The following is a description of a gene set: Neighborhood of FRK fyn-related kinase in the MORF expression compendium studied in species Homo sapiens Neighborhood of FRK Human Gene Set: MORF_FRK, and this is the list of marker genes: AVP, SAA4, ODF2, ORC4, MYBPH, OPHN1, SPAG8, SSX2IP, P2RY6, RPGRIP1, ASTN1, PPP6R2 (NCBI Gene Id 9701), ANGPTL7 (angiopoietin like 7), DCAF4, TBC1D31 (TBC1 domain family member 31), TCF15, KCNH1, FRK, CASQ2, AP4E1, AVPR1A, ADGRB3, HCG4, MYT1, UGT2B4, SCN2A, GABRA6, MATN4, ZNF177, RPGRIP1L, DFFB, ADAM7, ATRNL1, BAAT, SLITRK2 (SLIT and NTRK like family member 2), TNNI2, IFNA4, HDAC9 (histone deacetylase 9), LCT, KCNH7, PRORP, ATG4B, CRP, AKR1D1, LCAT, DCC, MINAR1, SPAM1, BRDT, KIAA0087, LCMT2, SLCO2A1, CUL3, VPS41, TRIM9, TNFSF11, IL9, SLCO1B1, GPR176, IREB2, DOC2A, ST8SIA4, TPH1, SNUPN, GK2, TCF21 (NCBI Gene Id 6943), PHTF1, RFPL1S, MLLT3 (NCBI Gene Id 4300), CNTF, SERPINA5, KALRN, NACAD, TBC1D12, MTRF1L, LRRTM2, EPHA7, KRT37, GRM8, DZIP1, EIF2B1, GCNT2, HOXD9, TMEM8B, AKAP4 (A-kinase anchoring protein 4), NMBR, H4C2, ZNF154, ART3, AKAP5, WIPF1, GPR4, ZNF208, PDCL (NCBI Gene Id 51420), CHRNA3, BMPER, RFX1, CBLIF, IFT88 (NCBI Gene Id 8100, intraflagellar transport 88), ZNF264, FAM13C, STBD1, MATCAP2, PSMD4P1, TAF4, PRM2, SERPINC1, DMP1, STARD13, RBM17